Given this list of marker genes SLC25A42, SLC25A16, VNN2, PPCS, ENPP2, PPCDC, COASY, ENPP1, PDZD11, AASDHPPT (NCBI Gene Id 60496), VNN1, PANK4, ENPP3, NUDT8, PANK2, PANK3 (NCBI Gene Id 79646), DCAKD, PANK1, SLC5A6, FASN, here is a description of the gene set: Vitamin B5 (pantothenate) metabolism species: Homo sapiens Human Gene Set: REACTOME_VITAMIN_B5_PANTOTHENATE_METABOLISM